The following is a description of a gene set: Abnormal epiphysis morphology An anomaly of epiphysis, which is the expanded articular end of a long bone that developes from a secondary ossification center, and which during the period of growth is either entirely cartilaginous or is separated from the shaft by a cartilaginous disk. Human Gene Set: HP_ABNORMAL_EPIPHYSIS_MORPHOLOGY species: Homo sapiens, and this is the list of marker genes: IFT172, SLC35B2 (NCBI Gene Id 347734), SLC26A2, COL10A1, ORC6, COL2A1, WNT5A, NEK9, NPHP1, COG1, NMNAT1, PRDM5, GDF5, TNFSF11, IHH, KIF7, EBP, PEX16, LHX3, DVL1, GORAB, DYNC2H1, IFT52, NPHP3, INPPL1, COL9A3, PORCN, FN1, CKAP2L, RUNX2, LTBP3, COL9A1, MMP9, MATN3, SMARCA2, UNC45A, ARSL, PEX10, TCIRG1, DUOX2, IFT80, PTH1R, IFT140, EVC2, EXT1, MEG3, FGF9 (fibroblast growth factor 9), EXTL3, ATR, SIK3, PEX11B, TSHB, EFL1, RAB3GAP2, SLC34A3, COMP, BGN, SNRPB, MIA3, AIFM1, KIF1A, CYP19A1, PROP1, KIAA0753, TRAF3IP1 (NCBI Gene Id 26146), TRAIP, SLC39A13, KIAA0586, GMNN, LMBR1, WNK1, DLK1, PEX5, LETM1, CLCN5, ADAMTSL2, ERI1 (NCBI Gene Id 90459), CDT1, KCNH1, FLNA, SMAD4, RAB33B, RSPRY1, PCNT, RAB23, GUSB, GALNS, NEK1, TREX1, ATRIP, HPGD, RAD21, PDE3A, FGFR3, CYP27B1, GLB1, WDR19, TONSL, ADAMTS2, HSPA9, NSMCE2 (NSE2 (MMS21) homolog, SMC5-SMC6 complex SUMO ligase), DHCR7, CSPP1, SCN9A, RETREG1, EIF2AK3, TINF2, VPS35L, DYNC2I2, PIK3CD, UFSP2, HOXA13, SIL1, PRKAR1A, PEX7, B3GALT6, RPS6KA3, XYLT1, DDRGK1, TG, PEX1, CDC6, FLNB, FBN1, SLC2A10, SOX9, BMPR1B, PLK4 (polo like kinase 4), CDC45, MRPS28, RINT1, CDKN1C, VDR, PEX3, PISD, CEP290, EVC, PIK3R1, GGCX, TRPS1, NPR3, PTPN11, NSDHL, TRPV4 (NCBI Gene Id 8098), SALL1, SRP54, SHOX, NUP85, CHST3 (NCBI Gene Id 9469), AGPS, PAM16, PEX2, SRCAP, CREBBP, DYM, SDCCAG8, PCYT1A, POU1F1, TBX4, FGFR2, RET, LBR, IDUA, KIF22, CANT1, TRIP11, PEX13, ZMIZ1 (NCBI Gene Id 57178), TTC21B, SMARCAL1, NPR2 (natriuretic peptide receptor 2), NKX3-2, SKIC3, CDC42BPB, BRF1, SLC10A7, MAFB, IQCB1, TMEM67, COL1A1, TGDS, DPYD, TPO, SBDS, DNA2, DNAJC21, CENPE, TYROBP, KIF15, COL1A2, PYCR1, BPNT2, NEU1, THRB, MAP3K7, FGFRL1, NOG, PIK3C2A, ORC1, MIR140, GPX4, RPL13, CPLX1, INVS, SNX10, LHX4, NPHP4, PLOD3, KNSTRN, GNPAT, ATP7A, RTL1, MGP, MMP13, CEP152, NSD2, HSPG2, POR, FZD2, DVL3 (NCBI Gene Id 1857), IYD, PEX6, BMP4, TREM2, GNPTG, CLCN7, CTBP1, ORC4, PHEX (NCBI Gene Id 5251), ERCC8, HESX1, ESR1, COL11A2, TSHR, EP300, OCRL (NCBI Gene Id 4952), RNU4ATAC, NANS, DUOXA2, RBBP8, IFIH1, P4HB, POC1A, CEP164, ACAN, PEX26, TRAPPC2, PDE4D, IARS2, DYNC2I1, ARSB, GEMIN4, PEX19, SLCO2A1, OFD1, CEP120, COL11A1, TMEM165, RMRP, PHYH, SLC5A5, ZNF469, TBC1D2B, HS2ST1, GNS, DYNC2LI1, ERCC6, COL9A2, PEX12, PEX14, PIGL, CYP2R1, CCN6, COG4 (component of oligomeric golgi complex 4), DDR2, LONP1, IFT122